Given this list of marker genes RPL32, PPP1R11, ATP6AP1, STMN2, FTL (ferritin light chain), SUMO2, BAG1, PCP4, MAPK8IP2, MOG (NCBI Gene Id 4340), CETN2, RNF11, UNC13B (NCBI Gene Id 10497), YWHAQ, INA, CCT7, KIFAP3, PKIG, ENSA, GABRD, SNN, BAIAP3, DHX30, TMEM147, CAMK2G, NECAB2, GLS, SLC35A1, ACD, SNRPB, SCN1B, SPOCK2, ANXA6, BCL7B, PSMD2, S100B, CCT8, SEPTIN8, PPP1R7, AREL1, KBTBD11, NECAP1, TSPOAP1, PUM2, NUAK1, KCNN1, STX1A, ARRB2, CHPF, GPRC5B, COPS7A, SLC3A2, BECN1, FAU, RABAC1, NSG2, NUCB1, RPL41, SMARCD3, NFE2L1, GAPDH, NELFE, CACNB3, CA11, EPS15, ATP5PO, RASSF2 (Ras association domain family member 2), STARD7, ABCA3, HYOU1, CLTB, TUBB4B, CLNS1A, IDH3B, RPL37, RTN1, CDK14, MBD3 (methyl-CpG binding domain protein 3), FAIM2, ATP5F1D, SSR4, LY6E, ANAPC5, UTP14C, SCG5, TCEAL4 (NCBI Gene Id 79921), PTGDS, ADGRB2, ITPKA, CAP1, RPS11, EIF3K, OAZ1, SNRPG, ENDOG, CABIN1, AP2S1, LGALS1, S100A1, EPB41L3, GABARAPL2, HAGH, PTPRN2, GABBR1, MAP1LC3B, NME3, TCTA, PSMC5, DDHD2 (NCBI Gene Id 23259), PFN2, ACOT7, ILK, IP6K1, ZNF580, MAPK3, GOT1, PPIA, PTPRN, CSTF3, PTPRK, GABRB1 (gamma-aminobutyric acid type A receptor subunit beta1), CAMK1, IQSEC3, EIF3G, GDI1, KLHL21, KIAA0232, RASA1, TPI1, VPS28, EIF6, TCEA2, BTBD3 (NCBI Gene Id 22903), PDHB, NPY, PMVK, RBM10, PRAF2, GOT2, SERPINI1, PRR36, RAB40B, SH3GL1, TKT, TUFM, TUBA3D, ITPA, MLLT11, SLITRK5, FXR2, CDH18, MAGED2, CD200, PFKP, PPID, NRGN, GRHPR, SELENOW, RPL35 (ribosomal protein L35), NRDC, RPL36AL, PIP5K1C, FAM193A, PTOV1, CCDC92, FBXO9, IRAK1, SYNGR3, RABGAP1, CD9, SNX6, RACK1, ADRM1, RNF44, AMPD2, LDHB, NDUFB5, DNAJC11, RPL8, SPTAN1, PEBP1, HDGF, NEDD8, SUMO1, PIN1, DAZAP2, SNRPA, TBC1D9, STAMBP, OAT, DMTN, VPS72 (NCBI Gene Id 6944), AMFR, ATRNL1, ARF3, HADHB, SLC4A3, COPE, RAP1GAP2, RCAN2, SLC20A1, UBE2M, OLFM1, TSPAN7, BLCAP, LASP1, CLASP2, FEZ1, CKB, MGRN1, ENTPD6, CBX7, ST3GAL5, TIMM17B, TMED2, PADI2, ACOT13, PTDSS1, TCFL5, CX3CR1, COX6B1, B4GAT1, ASIC2, NELL1, COX7A1, GGCT, TRIB2, PRDX1, DDB1, KRT10, SLC25A12, TRA2B, DCTN3, LYRM9, CLSTN1, STX12, FKBP1A, GAD1, TSC22D4, SPAG7, CX3CL1, STX7, SMARCA4, CLINT1, PPM1H, REEP5, MICAL2, CACNG3, NBL1, GLO1, ATP5MF, CYFIP2, EIF3F, VDAC3, NDN, LDOC1, APLP2, SNAP91, NCALD, SPHK2, ARFGAP2 (NCBI Gene Id 84364), TAC1, DPF2, ENPP2, ACTR1B, DPY19L2P2, VPS51, EFNB3, RNF103, EEF2, CAPNS1, PSMC1, AKT1, IRF9, CFL1, HIVEP2, RPL24, ARF5, MTX2, MIF, RRAGA, MRPL23, PARP1, DNAJB2 (DnaJ heat shock protein family (Hsp40) member B2), COBL, EEIG1, PSMB6, SARS1, RPL13, RNF4, VPS39, NDUFA7, IER2, POLR2J (RNA polymerase II subunit J), COX5B, TRIM37, PSMB5, GPX1, DAD1, BMERB1, PDHX, TTC1, PINK1, POLR2E, ME3, NCL, GNAZ, RUSC2, MTMR9, ECH1, FDPS, PLP1, AP3M2, ETFB, RUSC1, ANAPC13, NDEL1, CA2, FKBP1B, DEGS1, ASNS, PMM1, COX7C, UBA2, ALDOC, C1orf216, AFG3L2, ECHS1, CLDND1, NDUFV1, MAN2A2, NDUFS4 (NADH:ubiquinone oxidoreductase subunit S4), NREP, LANCL1, SHOC2, APLP1, PEF1, HRAS, COX7A2, RPS17, CDK5, CRY2, VPS52, UROS, FNDC4 (NCBI Gene Id 64838), VPS8, CDC16, NSF, PSMD7, SUCLG1, SDHA, ALDOA, RPS10, TATDN2, FAM98A, DHCR24, UBE2E3, SUMO3, ATP6V1E1, NDUFB8, USP11, STAT4, GABARAP, MYL6B, NDUFB1, SST, UQCRC1, ITGB1BP1, RPS27, CAPZA2, SPINT2, DSTN, EPHB6, NDUFA1, AHSA1, DCTN2, CRYM, PSMB4, DOCK3, NDUFAB1, PSMA6, WIPF2, SRP14, SERPINF1, MTMR6, RTL8C, LINC01963, WDR47, SNRPC, CORO2B, CSRP1, RNPS1, CHL1, MDH1, STOML1, AGPAT1, NMNAT2, NNAT, DOCK4, CABP1, TUBA1A, SAC3D1, BIN1, DRG1, RNH1, RPS8, UBB, DGKZ, BSN, RASL10A, AKR1B1, ACTR1A, COX6A1, WSB2, RPS27A, PRRC2B, DHPS, COX7A2L, CALM3, MIR9-1HG, NEFH, DHCR7, TRIM28, PNPLA6, PUF60, GNPDA1, TBCB, SULT1A1, SNRPD2, MAL, SUPT4H1, RPL27, TMEM59, CRYAB, RPS29, PPP2R1A, HPCAL1, APBA2, KIAA0513, ATP6V1F, PRPF8, PPP1CA, KIF21B, RUVBL2 (NCBI Gene Id 10856), MRPL40, PTPA, CYC1, GLRB, RNF187, RPL10A, AHNAK2, GATB, SLC25A3, CD74, ATP5MC1, TRAPPC12, NDUFS7, SHROOM2, CTSH, TUBA4A, NONO, GTF3C1, PPFIA4, PLAAT3, BTBD8, TAF6, RPS4X, C1QBP, CCT3, RIMBP2, COPS5, DDIT3, ESYT1, TAF10, ABHD14A, CLCN6, LGMN, CBX6, EGR3, TCP1, SCAMP3, IDI1, PGRMC1, GFAP, PAM, RHOA, PISD, SYN1, NCAN, DRAP1, MAST3, ATP6V0B, FAM89B, SCG2, SULT4A1 (sulfotransferase family 4A member 1), UQCRB, NDUFAF3, CNIH1, LMAN2L, MARCKSL1, PRR3, ATOX1, RPL11, ARHGEF17, NDUFS1, RAN, HCFC1R1, RPLP1 (NCBI Gene Id 6176), DCXR, DPYSL2, CDIPT, CORO1A, CTCF, DNM1, DENND4B, ARHGEF18, CREB3, BEX4 (brain expressed X-linked 4), SV2A, TALDO1, RNF41, SNRPE, SEM1, NCDN (neurochondrin), CHST15, HMGCR, CHMP1A, ELOB, BAG6, RUNDC3A, EIF4G2, NPC2, KLK6, MCF2L, KCNK1, SCAP, PGK1, RPL28, LAPTM4B, VIM, SFXN3, ELOC, CANX, COX17, RPS19, PCNT, STIP1, CTSA, PFDN1, ATP6V0C, NDUFC1, BBLN (NCBI Gene Id 95825), SNU13 (NCBI Gene Id 6743), CENPX, TMEM151B, RAD23B, UQCRQ, TUSC3, FARSA, SNCB, COX8A, HTRA1, CD81, STX4, SORL1, ATG9A, TUBB4A, ERP29, PSAP, AKR1A1, SLC25A11, GPX4, CHST1, ATP6V1B2, DTX4, GNAI1, BLOC1S1, FAM171A1, OMG, REEP1, ADAR, TAX1BP1, RPL29, NARS1, ISCU, SEC11A, PSMB3, ECI1, MAGED1, TMEM184B, ANOS1, CTDNEP1, AUH, WDR7, SPTBN2, RPS3, RAPGEF5, DBN1, AARS1 (NCBI Gene Id 16, alanyl-tRNA synthetase 1), CAMK1G, YARS1, PSMD8, PGAP4, PHF24, ERI3, AP3B2, ACTG1, DDOST, ANP32B, ATP6V0D1, WBP2, PFN1, ARCN1, PFDN5, ZMAT4, EIF2B4, TECR, GTF3A, MACROH2A1, BMI1, SYP, ARPC2, LAMTOR5 (NCBI Gene Id 10542), UCHL1, SLC25A4, CSTB, SEC14L5, NTHL1, BAP1, SF3B2, ALDH2, FIBP, FXYD7, PTS, GAB2, MADD, COX4I1, HPCA, DNAJB1 (DnaJ heat shock protein family (Hsp40) member B1), AHCY, CHMP2A, IPCEF1, COX5A, ECSIT, TUSC2, DDX42 (NCBI Gene Id 11325), ARNT2, ENO2, ARFIP2, CCK, DYNC1H1, TCEAL1, NAGPA, RGS7, EID1, FIG4, MYRIP, PAFAH1B3, HAX1 (NCBI Gene Id 10456), AP2M1, UBA1, RPL3, RPS16, JOSD1, NCOA4, SEZ6L2, PSMB10, HMGN1, UQCRFS1, SOD1, NCKAP1, ACTL6B, PPP2R5B, HECTD4, GNAS, ARL4A, NPTXR, NDRG1, SLC25A6 (solute carrier family 25 member 6), LRPAP1, SACM1L, LTA4H, NPTX1, BCAP31, CLTA, IMPDH2, MSL1, MRPL49, NDUFB3, TUBB2A, RIMS3, RPS12, ATP6V0E2, LSM7, FTO, TRAP1, FOXG1, THY1, OS9, FADS2, EIF3D, SSNA1, TOMM34, HINT1, NDUFS8, EXOC3, PPP1R16B, TSNAX, SLC30A9, STK24, CDC34, SNTA1, DEAF1, PES1, CAMK2B, PDE2A, HSPD1 (heat shock protein family D (Hsp60) member 1), NIPSNAP1 (nipsnap homolog 1), RPRD2, DCLK1, DGUOK, GPR162, SYT11, MIR124-1HG, NDUFS3, EFR3A, CCT2, ENO1, STXBP1, MNT, FXYD1, NUDC, FAN1, HMCES, NUP93, PCSK1, TUBB3, KDM1A, TNFSF12, ASS1, ZNF365, PSMD10, HADHA, B3GAT1, ELMO1, ATP5F1C, GPI, CSNK2B, CRMP1, UQCRH, KCNF1, PAK6, RTN2, SERP1, CIRBP, here is a description of the gene set: Human Gene Set: KIM_ALL_DISORDERS_OLIGODENDROCYTE_NUMBER_CORR_UP Genes whose expression was significantly and positively correlated with the number of perineuronal oligodendrocytes in the layer III of BA9 brain region. studied in species Homo sapiens Cytoarchitectural abnormalities have been described in the prefrontal cortex of subjects with schizophrenia, bipolar disorder and depression. However, little is known about the gene expression profiles associated with these abnormalities. Genome-wide expression profiling technology provides an unbiased approach to identifying candidate genes and biological processes that may be associated with complex biological traits such as cytoarchitecture. In this study, we explored expression profiles associated with the abnormalities by using publicly available microarray metadata and cytoarchitectural data from post-mortem samples of the frontal cortex from 54 subjects (schizophrenia, n=14; bipolar disorder, n=13; depression, n=12 and controls n=15). Correlation analysis between genome-wide expression levels and cytoarchitectural traits revealed that genes were significantly correlated with a decrease in the number of perineuronal oligodendrocytes across all subjects. A total of genes were significantly correlated with a decrease in density of calbindin-positive interneurons across all subjects. Multiple biological processes including cellular metabolism, central nervous system development, cell motility and programmed cell death were significantly overrepresented in both correlated gene lists. These findings may provide novel insights into the molecular mechanisms that underlie the cytoarchitectural abnormalities of perineuronal oligodendrocytes and calbindin-containing GABAergic interneurons in the prefrontal cortex of the major psychiatric disorders. from publication Kim S, Webster MJ (PMID 18762803)